The following is a description of a gene set: Human Gene Set: HP_SUPERNUMERARY_SPLEENS The presence of two or more accessory spleens. Supernumerary spleens studied in species Homo sapiens, and this is the list of marker genes: CLXN, DNAH5, ODAD4, GPC3, DNAJB13, WT1, DNAAF5, STK36, RPGR, GPC4, CFAP298, FOXJ1, HYDIN, LTBP4, OFD1, SPAG1, PRIM1, CPLX1, TMEM237, CFAP74, CCNO, DNAH11, CCDC40, ZIC3, PPP2R3C, CFC1, DNAAF6, GAS2L2, LETM1, CTBP1, MEGF8, CDON (cell adhesion associated, oncogene regulated), TMEM216, RFWD3, DNAAF4, ODAD3 (NCBI Gene Id 115948), HYLS1, RPGRIP1L, DNAH1, NME5, DNAAF2, RSPH1, MCIDAS, DNAI2, DNAI1, CCDC39, B9D1, RPGRIP1, EXOC2, SPEF2, TCTN1, TMEM231, LRRC56, CEP290, TCTN3, CREBBP, MYCN, TMEM67, DNAL1, B9D2, ODAD2, ACVR2B, CFAP45, FGFRL1, EP300, DNAH9, ODAD1, NSD2, ATP6AP1, RAB23, RSPH3, WDR35, DRC1, DNAAF11, ESCO2, CC2D2A, YARS1, TTC12, TXNDC15, GDF1 (growth differentiation factor 1), NEK10, MKS1, MMP21, DNAAF1, RSPH9, MYRF, CFAP221, DNAAF3, TMEM107, TCTN2 (NCBI Gene Id 79867), NPHP3, RSPH4A, NME8, CSPP1, CENPF, ZMYND10, CFAP300